The following is a description of a gene set: Any process that activates or increases the frequency, rate, or extent of toll-like receptor 2 signaling pathway. studied in species Homo sapiens Human Gene Set: GOBP_POSITIVE_REGULATION_OF_TOLL_LIKE_RECEPTOR_2_SIGNALING_PATHWAY, and this is the list of marker genes: PJA2, F2RL1, HMGB1, TIRAP, TLR1, CYBA, MFHAS1